The following is a description of a gene set: Human Gene Set: WP_GASTRIN_SIGNALING studied in species Homo sapiens Gastrin signaling, and this is the list of marker genes: MAPK8, CCND1, RAC1, KLF4 (NCBI Gene Id 9314), CHGA, PXN, CDC42, JUN, MAP2K1, GNAQ, MAPK14, GRB2, PIK3R2, PRKCD, JAK2, SP1, RPS6, SERPINB2, BCL2L1, CDKN1B, EIF4EBP1, MAPK3, SHC1, JAG1, BAD, PRKCH, CXCL8, ANXA2, BIRC2, BORCS8-MEF2B, SLC9A3, RAF1, MAPK9, PPARG, PLCG1, RPS6KB1, RHOA, BIRC3, IKBKB, CREB1, TJP1, PRKCQ, CCKBR, CASP3, NFKBIA, EGFR, STAT3, PAK1, BMP2, ELK1, SERPINE1, RHOD, KIT, ITGB1, TCF4, FOS, ARRB1, ELAVL1, GSK3B, MTOR, YES1, ROCK1, KRAS, PIK3R1, BIRC5, CLDN1, PRKACA, GAST, PRKD2, LAMTOR3, FOXO3, EGR1, ARRB2, TFF2, ATF2, HDC, FOXO1, CD44, FYN (FYN proto-oncogene, Src family tyrosine kinase), PTPN11, PIK3R3, SOS1, PRKCA, ARHGEF28, HRAS, NFKB1, RELA, MAPK1, RHOB, CDKN2A, PTK2, VEGFA, SRC, IRS1, BCAR1, AKT1, KAT5, PIK3CA, MAP3K11, CDH1, MEF2B, MMP7 (NCBI Gene Id 4316), SLC9A1, PRKD1, PTGS2, CHUK, CRK, MYC, MEF2D, HDAC7, MEF2C, CDKN1A, PRKCE (NCBI Gene Id 5581, protein kinase C epsilon), IL2, CTNNB1